Given this list of marker genes ORC1, WNT7A, SOX5, MADD, KRAS, JAG1, ACVR1, NXN, MNX1, GPC4, ZIC3, RIPPLY2, BAZ1B, DPYSL5, WBP11, NOTCH3, MBD5, PAICS, CLIP2, WASHC5, PTCH1, DNAJC30, BUD23, SMAD4, METTL27, TPM2, FREM2 (FRAS1 related extracellular matrix 2), NSD2, RBM8A, KYNU, RAD21, NOG, MBTPS2, TNNI2, FZD2, TBX2, TNNT3, WNT5A, DNAL4, MYH3, MID1, DLK1, FANCI, DLL3, RFC2, GLI3, HGD, CCDC22, FN1, MAP3K7, BRPF1, HES7, KANSL1, VANGL1, SON, NADSYN1, ABCC6, GTF2I (general transcription factor IIi), SALL4, TBC1D24, ANKRD11, ASXL2, CHN1, FKRP, HNRNPK, FKBP6, SUFU, SIX6, FUZ, ATRX, GTF2IRD2 (GTF2I repeat domain containing 2), VPS35L, WNT4, FGFR1, IKBKG, ACTB, CHRND, DKK1, PUF60, LFNG, NALCN, DPP9, GDF6, FRAS1, LYSET, CPLX1, SEMA3E, CDK10, LETM1, TBL2, GTF2IRD1 (NCBI Gene Id 9569), HNF1B, SF3B2, MEG3, RTL1, POR, EIF5A, NRAS, COL2A1, BMPER, FLNA, NTN1, VPS37D, CDC45, STX1A, ELN, TAF1, GPC3, KMT2D, AFF4, CHRM3, HRAS, FANCB (NCBI Gene Id 2187), DVL3, FGFRL1, EBP, DVL1, TBX5, CHD4, MAFB, CHRNA1, CDH11, ENPP1, LIMK1, MEOX1, STAG2, TMCO1, NCF1 (NCBI Gene Id 653844), CHRNG, PTDSS1, FGFR2, GDF5, CHD7, IL1RN, COG1, TMEM270, ATP6V1B2, DCC, GNPTAB, RAD51, GRIP1, FGD1, KDM6A, TBX6, ASH1L, EIF4H (NCBI Gene Id 94573, eukaryotic translation initiation factor 4H), PTCH2, AEBP1, B3GLCT, HOXD13, MESP2, MYO18B, CTBP1, FLNB, SOX2 (NCBI Gene Id 6657), CAPN15, LRP4, GDF3, PLOD2, H3-3B, ROR2, here is a description of the gene set: Vertebral segmentation defect An abnormality related to a defect of vertebral separation during development. species: Homo sapiens Human Gene Set: HP_VERTEBRAL_SEGMENTATION_DEFECT